Given this list of marker genes Afg3l1, Rex1bd, Tm9sf4, Usf2, Tfap4, H2-M5, Vipas39, Tmem231, Fbll1, Ahsa1, Fignl1, Zfp395, Chchd2-ps, Gapdh, Spag5, Glra1, 4930478K11Rik, Brpf1, Ier2, Triap1, Ccdc174, Vps72, Sinhcaf, Mapk8ip2, Rph3a, Cdh13, Gm13110, Cacng2, S100pbp, Smad7, Atf7ip, Trp53cor1, Gm24452, Pde4d, Abcf3, Tbx3 (NCBI Gene Id 52240), Psmc4, Satb2, Psmd13, Mir7668, Stx1a, Mir7b, Tspan18, Dpep3, Prrc2a, 5031434O11Rik, Capza1, Map6, Snord60, Hsp90ab1, Clasp1, Hilpda, C330002G04Rik, 1500015A07Rik, Sdf2, Mbtps2, A630072M18Rik, Spry4, Abtb3, Neurod4 (NCBI Gene Id 11923), Arpc3, Arhgap26, D030068K23Rik, Ino80d, 9430015G10Rik, Lars1, Phf21a, Scrt1, Uba52, Gprin1, Tcea2, Gm15927, Gm5251, Ptbp1, Ipo13, Gfra2, Hspa4, Slc39a3, Barhl1, Gm25894, Ppp1cb, Tent2, Ptp4a1, Tbx3os1, Thap1 (NCBI Gene Id 73754), Penk, Ywhag, Nktr, Rexo2 (RNA exonuclease 2), Zfp27 (NCBI Gene Id 22689), Arl15, 4930540M05Rik, Shmt1, Rab26os, Yars1, Nr1h4, Gm26705, Vps4a, Dhps, Mrpl14, Ino80dos, Gm25855, Abhd13, Traf7, Slc9a8, Xpo1, 4933440N22Rik, Wdr75, Sfi1, Gm20544, Agap3, Omg, Psma3, N4bp2l2, Hes1 (hes family bHLH transcription factor 1), Rfwd3, Zfat, Mlxip, Cyb5r4, Atp5f1a (NCBI Gene Id 52533), Magt1, Srsf1, Slc3a2, Nabp1, Depdc5, Cyp51, Ube2i, Adck1, Hyls1, Borcs5, here is a description of the gene set: Mouse Gene Set: ZFP984_TARGET_GENES species: Mus musculus from publication Yevshin I, Sharipov R, Kolmykov S, Kondrakhin Y, Kolpakov F (PMID 30445619)